The following is a description of a gene set: Enables the transfer of succinate, the dianion of ethane dicarboxylic acid, from one side of a membrane to the other. studied in species Mus musculus Mouse Gene Set: GOMF_SUCCINATE_TRANSMEMBRANE_TRANSPORTER_ACTIVITY, and this is the list of marker genes: Slc13a3, Slc25a10, Slc13a2, Slc16a1, Slc13a5